Given this list of marker genes VAMP4, NOP10, SPG21, GATAD2A, ZC3H11A, ALAD, ATAD1, LITAF, BMAL1, UBAP2L, C5orf34, SNHG6, ST6GALNAC4, PADI4, ZMYM6, SQOR, GGNBP2, MTIF2, SNRPB2, PIGX, DPP7, MRPL35, ITLN1, VPS52, MTMR9, DDOST, TTC7B, TFPI, KIF1C, CRYZ, TBCB, MYOM1, CREG1, GPI, GGH, CLEC16A (C-type lectin domain containing 16A), FGF3, DBI, DCTN6, PYHIN1, NECAP2, USP38, D2HGDH, NUB1, SERF2, MPO, ACADL, SRP9, SNORD30, CSRP1, TM2D3, HDC, PITX2, MED1, PDXDC1, HLA-DRA, SC5D, HARS1, RCN1, PADI2, LIG3, ARL6IP1, CTSE, NSDHL, CUX1, CNIH1, GLO1, ATP5MJ, IL3RA, CBFA2T2, CD59, ATP6V1B2, AGTRAP, IFI16, GFER, PSMB6, CST3, MPC2, CNN3, CPSF2 (cleavage and polyadenylation specific factor 2), FLOT1, ALDH9A1, PRDX2, CTSC, THUMPD1 (THUMP domain containing 1), PTPRVP, GNB1, TSPAN8, MYL10, SARAF, MYO5A (myosin VA), GNB4, NVL, ADPGK, F2R, RPL26, NPL, TMEM234, TUBGCP4, COA3, FLI1, NABP1, EMP1, DAP3, TMCO1, NFYA, DIAPH3, PSMG4, GATM, CD1D, MRPS7, SCOC, CCND2, PON2, MSH5, F11R, RUNX1, OCEL1, NSMCE3 (NCBI Gene Id 56160), RGCC (NCBI Gene Id 730127), GCSAM, TRAPPC12, SPAST, CCL15, F5, GEMIN5, ELOA, PTPRF, CCR2, TUBB6, HJURP, ADGRG1, CBR1, here is a description of the gene set: species: Mus musculus Human Gene Set: BYSTRYKH_HEMATOPOIESIS_STEM_CELL_QTL_CIS Transcripts in hematopoietic stem cells (HSC) which are cis-regulated (i.e., modulated by a QTL (quantitative trait locus) in close proximity to the gene). We combined large-scale mRNA expression analysis and gene mapping to identify genes and loci that control hematopoietic stem cell (HSC) function. We measured mRNA expression levels in purified HSCs isolated from a panel of densely genotyped recombinant inbred mouse strains. We mapped quantitative trait loci (QTLs) associated with variation in expression of thousands of transcripts. By comparing the physical transcript position with the location of the controlling QTL, we identified polymorphic cis-acting stem cell genes. We also identified multiple trans-acting control loci that modify expression of large numbers of genes. These groups of coregulated transcripts identify pathways that specify variation in stem cells. We illustrate this concept with the identification of candidate genes involved with HSC turnover. We compared expression QTLs in HSCs and brain from the same mice and identified both shared and tissue-specific QTLs. Our data are accessible through WebQTL, a web-based interface that allows custom genetic linkage analysis and identification of coregulated transcripts. from publication Bystrykh L, Weersing E, Dontje B, Sutton S, Pletcher MT, Wiltshire T, Su AI, Vellenga E, Wang J, Manly KF, Lu L, Chesler EJ, Alberts R, Jansen RC, Williams RW, Cooke MP, de Haan G (PMID 15711547)